Given this list of marker genes Vmn1r181, S100a2, Slc2a3, 1700023H06Rik, Kntc1, Gm15426, Cryz, Tmem183a, Topbp1, Fiz1, Aste1, Avpi1, 2210011K15Rik, Bad, Wscd2 (WSC domain containing 2), Cp, BB187690, Gm42745, Rdm1, Snord118, Gm29414, Cdpf1, Slc2a2, Gm6822, Ugt1a6a, Cd68, Gm24873, Ypel1, Gm10373, Gm7285, H2ac7, Zcchc3, Capg, 1110002J07Rik, Sag (S-antigen, retina and pineal gland (arrestin)), 2600014E21Rik, S100a4, Alkbh3os1, 2310005E17Rik, Bcl2l13, 9130230L23Rik (NCBI Gene Id 231253), Arpc5, Arid5b, Fbxo10, Nemp2, Ppm1f (NCBI Gene Id 71214), Gm3646, Cpa4, Zfp595, Nrxn1, Snhg16, Get4, Cdk15, Gpr137, Umad1, Atf1, Smu1, Sp1, Mat2a, Uso1 (NCBI Gene Id 56041), Prelid3b, Prex1, Dhps, Snx27, Dcaf15, H2bc7, Atf7ip, Ifi47, Or5m11b, Mzt2, Mir1956, Ifi27, Nfe2l1, Dab1, Zfp617, Tomm40l, Lims1, Rbm19, Slc8b1, Gm15579 (predicted gene 15579), Sox9, Oard1, D3Ertd751e, Gm13598, Gm12056, Nek11, Gm8883, Mfsd14b, B530045E10Rik, H2-M3, Gm7626, Emc2, Rsrp1, Ergic2, Krtap1-5, Eif4e, Zfp882, Rwdd4a, Zfp524, 4931440P22Rik, Arrdc3, Ddx20, Polr3h, Cavin2, Hexim2, Gm40323, Tardbp, Pbld2, Ankrd17, Snn, Steap3, Ppara, 4933406D12Rik, Ywhaz, Ms4a5, Prok1, Mtfr1, Snord138, Gls, Clec10a, Zbed5, Gm10750, Kdm5b, Tcaim, Ccl9 (C-C motif chemokine ligand 9), 6820408C15Rik, Wdr18, Stk25, Lmbrd1, Gm12993, Gm25769, Tspan31, Mrnip, Mir6397, Zfp512, Gm25502, 2310043O21Rik, Gm12222 (NCBI Gene Id 260348), Gm5354, Rab11fip4os2, 3110070M22Rik, Phactr1, Gm12648, Gm12602, Ppp4r3b, Nfya, Ark2c, Ttc32, Slc19a2, Gm13652, Cbr3, Gm15731, Sh3bp4, Ncf2, Smpd4, Exoc7, Znhit3, Sec14l1, Gm26490, Litaf, Scoc, Serpinb1-ps1, Socs1, Sgk2, H2ac21, Cflar (NCBI Gene Id 98571), Mmp2, Bcas1, Ralgds, Mob4, Arhgap26, Vim, Ptpn22 (protein tyrosine phosphatase, non-receptor type 22 (lymphoid)), Ubxn8, Gm10701, Meg3, Mospd3, Ubald2, Stip1, Lamc2, H3c13, Zfp365, Zfand1, Gm10484, Plscr1, Mbd3, Sclt1, Gnas, Uvrag, Clk1, Cyp51, Fryl, Smchd1 (SMC hinge domain containing 1), Gm27005, Bola1, 2310022A10Rik, Bri3, Axin2, Fxr2, Col4a3, Gm9687, Snx29, Rps6ka2, Cyld, Ehmt1, Ppp1r15b, Aph1a, Shb, Clcn3, Polr2g, Hnrnph3, Medag, Prrc2a, BC006965, Rabl3, Gm24499, Kmt5a, Ppp2r1b, Cnbp, Trafd1, Timm10, Gm6520, Ank3, here is a description of the gene set: studied in species Mus musculus Genes containing one or more binding sites for (Duxbl1) in their promoter regions (TSS -1000,+100 bp) as identified by GTRD version 20.06 ChIP-seq harmonization. from publication Yevshin I, Sharipov R, Kolmykov S, Kondrakhin Y, Kolpakov F (PMID 30445619) Mouse Gene Set: DUXBL1_TARGET_GENES